The following is a description of a gene set: species: Homo sapiens Binding to nicotinamide-adenine dinucleotide phosphate, a coenzyme involved in many redox and biosynthetic reactions; binding may be to either the oxidized form, NADP+, or the reduced form, NADPH. Human Gene Set: GOMF_NADP_BINDING, and this is the list of marker genes: FMO1, GLYR1, GMDS, CRYZ, CAT, CBR3, GAPDH (glyceraldehyde-3-phosphate dehydrogenase), HSD11B1, ASPDH, SPR, NOS2, DHFR, DUS2, TP53I3 (tumor protein p53 inducible protein 3), SRD5A1, CRYZL1, HSD17B1, DUOX1, FMO2, NOS3 (NCBI Gene Id 4846), PGD, ME1, NOX5, NDOR1, FMO5, MTRR, DHFRP1, AKR7A3, NOX1 (NCBI Gene Id 27035), DHFR2 (dihydrofolate reductase 2), GRHPR, MTHFR, FMO3, IDH1, CRYM, CBR4, DHCR7, HIBADH, POR, CYBB, FMO4, HMGCR, DPYD, GAPDHS, KCNAB1, NNT, QDPR, TM7SF2, LBR, G6PD, NOS1, ME3, GSR, DECR1, H6PD, KDSR